The following is a description of a gene set: Human Gene Set: HP_HERNIA Hernia studied in species Homo sapiens, and this is the list of marker genes: PLD1, TMCO1, COLEC10, PIGY, ESS2, GTF2IRD1, SET, GMNN, SMARCA2, HOXC13, AEBP1, ELOVL4, IFT81, SMAD4, IFT122, FANCM, PNKP, RFX7, KCNA1, FANCI, IPO8, RAC1, HIVEP2, CARS1, NELFA, LDHD, BRAT1, MED12, RIPPLY2, GNPTAB, LRPPRC, TGDS, SLC25A22, MAN2B1, SUZ12, DGCR6, CDC42, CAPRIN1, B3GLCT, BRIP1, COL11A2, NPHP3, SEMA5A, MTHFR, HYLS1, FANCD2, PIGS, SOX11, AMH, GORAB, ARID2, RAB23, GPC4, FRAS1, MECP2, UHRF1, ARID1A, DNMT3A, TMEM94, NSD2, FTO, BRD4, LFNG, DLX4, TGFBR1, PIGL, ZFPM2, PAFAH1B1, GLRA1, MEG3, GATA4, SLC5A6, SLC26A4, RNU4-2, ARID1B, PALB2, DGCR2, PHGDH, DVL3, STAG2, SETBP1, SMARCA4, SMC3, TRRAP, HES7, PIK3R1, CHST14, CDKL5, KMT2D, C1S, FANCC (NCBI Gene Id 2176), PROP1, LIMK1 (NCBI Gene Id 3984), PLCB4, FANCF, MAF, AUTS2, CD96, KMT2C, MAD2L2, BMPER, SRCAP, SLC37A4, VANGL2, TG, PPP2R1A, ODC1, GTF2I, IFT56, MYH11 (NCBI Gene Id 4629), GLB1, PYCR1, FOXF1, COL11A1, NSDHL, CHST3, NEK9, MED25, NR2F2, ZIC3 (Zic family member 3), SMCHD1, KIAA0586, TNXB (tenascin XB), STRA6, HMGA2, DYNC2I2, CDC42BPB, GLIS3, GJA1, PUF60, DPF2, HGSNAT, THSD4, UBE2T, CBS, FOXE3, MDFIC, SGSH, SPECC1L, ATP6V1E1, TSHR, KCNH1, FGFR2, IGF2, KDM5B, ERMARD, CHUK, DNAJC30, IFT80, FUCA1, OFD1, RAB3GAP2, GNE, CHD3 (chromodomain helicase DNA binding protein 3), TOR1A, PIGN, TSHB, ZBTB7A, RIN2, CDH11 (cadherin 11), GDF11, NUP107 (NCBI Gene Id 57122), HEY2, PIGW, LHX3, CHAMP1, KDM6A, P3H1, KDM3B, EOGT, FREM2, MAP1B, COL1A2, ANTXR1, MEGF8, HDAC4, GTF2H5, GAD1, TMTC3, WT1, RAD51C, H4C3, DIS3L2, KNSTRN, TTC7A, SCN1B, BRCA1, H19, TFE3, FOXE1, MED13L (NCBI Gene Id 23389), AR, TRAIP, DYNC2H1, DLK1, ATP1A2, GDF1, COMT (NCBI Gene Id 1312, catechol-O-methyltransferase), ATRX, IFT140, PPP2CA, YWHAE, PIK3CD, EED, WDR35, SATB2, EFNB1, TARS1, TENT5A, MYH3, ZFX, TP63, NEUROD2, NOTCH2, COL1A1, EZH2 (NCBI Gene Id 392834), MSX1, ATP6V1A, DUOXA2 (NCBI Gene Id 405753), TASP1, MASP1, PAX8, FANCG, PLS3, UBA1, ABCC8, IDUA, DEPDC5 (DEP domain containing 5, GATOR1 subcomplex subunit), BCL11B, ADAMTS15, NFIX, LHX4, WNT7B, ATAD1, MCTP2, ISL1, SLC2A10, SHPK, WNK3, VPS37D, SEC24C (NCBI Gene Id 9632), LONP1, MYRF, IRX5, ALDH1A2, PRKG2, SNIP1, GRM7, SIK1, RPS26, GPC6, PPP2R3C, CLDN19, RLIM, NECTIN1, BRCA2, FGFR1, SOX4, XRCC2, CCDC22, SLC29A3, MN1, SCN2A, SEC31A, GRIN2B, KCNQ1OT1, UFD1, PIGQ, LTBP4, MAPK1, TRIM8, ADAT3, TRAF7, IDS, SMARCB1, GNS, DICER1 (dicer 1, ribonuclease III), BHLHA9, CPLX1, TGFBR2, RPS6KA3, PLOD2, DNAJC21, FKBP14, EFEMP2, MBTPS2 (NCBI Gene Id 51360), TMEM216, DNAJB4, MTFMT, TBX3, MYLK, DPH1, RIC1, FREM1, EXT2, SF3B4, MID1, GATA6, ELMO2, TWIST2, CASK, RNF113A, GON7, PACS1 (phosphofurin acidic cluster sorting protein 1), MKS1, SH3PXD2B (NCBI Gene Id 57517), ERI1, HIRA, THRA, PIEZO2, BAZ1B, COX11, WASHC5, ARSB, ATP7A, PLAG1, OCRL, NAA10, FKBP6, SLC26A2, NSD1, SMARCE1, NLRP3, NOTCH1, EFEMP1, COX7B, POU1F1, DHCR7, TGFB3, HOXD13, PTDSS1, GNPAT, G6PC3, GTF2IRD2, METTL27, INPP5E, STX1A, LBR, PLAGL1, COLEC11, NXN, PI4KA, BUB1, HIC1, HELLS, LTBP1, KCNQ1, LAGE3, AMHR2, ALDH18A1, ERCC4, VPS35L, RIPK4, NCF1, GLRB, BGN, TCF4, GUSB (glucuronidase beta), DPP9, GPC3, ZNF699, TUBB, ABL1, ROR2, TMEM107, DMXL2, TGFB2, COL3A1, ABCC9, DYRK1A, PPP1R12A, CLIP2, CDCA7, TAF4, FBXW11, CC2D2A, FBN1, FANCE, JMJD1C, RFWD3, MLXIPL, MBTPS1, COL5A1, TRPV6, KCNJ11, WNT5A, NDUFAF5, NEU1, NAT8L, WNT3, RAD51, SIN3A, SERPINH1, ALG9, SLC25A24, NKX2-1, MESP2, NFIA, RNF2, MFAP5, TNRC6B, TBX1, CTBP1, PTCH1, NDUFA8, FANCA, TPO, TPRKB, SLC10A7, GPHN, HDAC8, AGPAT2 (NCBI Gene Id 681), GZF1, PIK3CA, EHMT1, FGD1, ZEB1, BSCL2 (BSCL2 lipid droplet biogenesis associated, seipin), GTF2E2, RFC2, WDR4, PORCN, ARF1, GRIP1, CSNK2A1, ZNF469, AP1S2, CTCF, DNMT3B, HSPG2, AMER1, BRF1, CWC27, IRF6, FBXL4, BUD23 (NCBI Gene Id 84118), AGA, ACTG2, CUL4B, SHOC2, SLC32A1, FANCB (FA complementation group B), GNAO1, VPS33A, DLL3, NIPBL, RTL1 (NCBI Gene Id 651665), MMP2, POLR3GL, IYD, NALCN, PBX1, NOTCH3, RPS28, PLOD1, LETM1, RSPO2, POGZ, RPL10, FANCL (NCBI Gene Id 55120), ACTB (actin beta), ERCC3, ERCC2, TMEM270, DUOX2, RNF13, PPIB, ADNP, TMEM67, LMOD1, RREB1, SMARCD1, MPLKIP, GNB2, CDKN1C, SMC1A, WLS, SALL1, SKIC2, B3GAT3, MAFB, GP1BB, DPH2, SLC6A5, WNT4, SLC35C1, RAP1B (RAP1B, member of RAS oncogene family), MMP14, MAPRE2, CAMTA1, POLR2A, KIF7, KCNJ8, RAD21, MAT2A, POLR1A, MTOR, OCLN, DVL1, SMAD2, TXNL4A, CHD7, MEIS2, DGCR8, ZFP57, TMEM70, GRIN1, C1R, PIGP, CLCN4, FIBP, CREBBP, TBL2, PRR12, FAT4, ADAMTS2, SMAD3, DDX6, FARSB, SLC5A5, CRELD1, CHRNG, SKI, CCBE1, PRDM5, IKBKG, SH2B1, ARVCF, ELN, DYNC2I1, ARPC4, SLX4, DACT1, OSGEP, ARFGEF2, EN1, AHDC1, ANAPC7, PRKG1, FLNB, DSE (NCBI Gene Id 29940), HESX1, FZD2, BMP1, NUAK2, RARB, NUP133, ARX, NEDD4L, RPGRIP1L, EIF4H, CAMSAP1, CRKL, GLI3, FLNA, HYMAI, XRCC4, SLC35D1, NDUFB11, NKX2-5, WDR19, DPYSL5, CTNND2, HCCS, MAP3K7, ABCD4, GALNS, CEP120, BCOR, SMARCC2, FLI1, MYT1L, TP53RK, COL5A2 (collagen type V alpha 2 chain), FOCAD, YRDC, TAF6, SKIC3, LOX, PPM1D, FBLN5, PIGG (NCBI Gene Id 54872), BCR, TRIP11, MAMLD1, AARS1, LRP2, SOX6, APC2, ZBTB24, SEMA3E, ACTA2, ATP6V0A2, ADAMTSL2, WDR73, COL2A1, PCNA